Given this list of marker genes HTR7, LRRC41, CUL3, CCNE1, RHOBTB3, RAB9B, VHL (von Hippel-Lindau tumor suppressor), PLIN3, RAB9A, HGS, here is a description of the gene set: part of: Signaling by Rho GTPases, Miro GTPases and RHOBTB3 RHOBTB3 is a member of the Ras-like superfamily of proteins that is phylogenetically distinct from other related Ras-like families, which include, besides RHOBTB3, Rho, Miro, Ras, Ran, Arf and Rab. Due to its similarity with RHOBTB1 and RHOBTB2 Rho GTPases, RHOBTB3 is sometimes classified as an atypical member of the RHO GTPase family. However, the GTPase domain of RHOBTB3 is divergent from other Ras-like superfamily members and actually displays ATPase activity. All three RHOBTBs possess other conserved domains in addition to the GTPase domain. The GTPase domain at the N terminus is followed by a proline rich region, a tandem of two BTB (broad complex, tramtrack, bric à brac) domains, and a conserved C terminal BACK (BTB and C terminal Kelch). Unlike RHOBTB1 and RHOBTB2, RHOBTB3 has a CAAX box (prenylation motif) domain. RHOBTB proteins can form homo and heterodimers, but the role of dimerization in RHOBTB function is not known. RHOBTB3 is ubiquitously expressed, with high levels in placenta, testis, pancreas, adrenal and salivary glands and neural and cardiac tissues. RHOBTB3 is involved in CUL3-dependent protein ubiquitination. RHOBTB3 is involved in retrograde transport from endosomes to the Golgi apparatus. RHOBTB3 participates in regulation of the cell cycle and in modulating the adaptive response to hypoxia. RHOBTB3 level is decreased in many tumor types and it is proposed to act as a tumor suppressor, although no pathogenic mutations have been reported. studied in species Homo sapiens Reactome Pathway: RHOBTB3 ATPase cycle